Given this list of marker genes Adra2a (adrenergic receptor, alpha 2a), Adra2b, Adra2c, Gng10, Gng4, Gng7, Gng11, Gngt2, Gnaz, Adcy5, Gng5, Gng3, Gnb5, Gnb2, Adcy8, Rgs16, Gng8, Adcy7, Gngt1, Gnb3 (guanine nucleotide binding protein (G protein), beta 3), here is a description of the gene set: part of: GPCR downstream signalling This event has been computationally inferred from an event that has been demonstrated in another species.<p>The inference is based on the homology mapping from PANTHER. Briefly, reactions for which all involved PhysicalEntities (in input, output and catalyst) have a mapped orthologue/paralogue (for complexes at least 75% of components must have a mapping) are inferred to the other species. electronically inferred by orthology from the curated human pathway Reactome Pathway: G alpha (z) signalling events studied in species Mus musculus